Given this list of marker genes RNA5S6, LUZP2, RCBTB2, ADAT2, PGM5P2, MYC, KCNAB2, PTGES3L, SNX16, NPEPL1, TRBV7-7, LINC00887, LINC00310, IQCE, ST8SIA6-AS1, TRHR, SPATA42, BASP1, NRSN2-AS1, GPHA2, LINC02645, SELENBP1, OPN4, ACSF2, NRG2, NDNF, GOLGA6L22, KIAA0319, APLP1, SLC24A4, MMP16, HYCC1, C4orf17, BLK, GABRA1, AMPH, OTP (NCBI Gene Id 23440), GAL3ST4, TTC9-DT, OTOG, KIF9, LINC02000, NRSN2, NOX4, SLC25A15, AMOTL2, NT5DC4, DUOX1, HSPA8P14, TRPM8, LHX8-AS1, TMEM95 (NCBI Gene Id 339168), SNORD13D, DENND4B, COL11A1, USP30, AMPD3, CTSK, ADGRG1, RD3, TTC9, MTRES1P2 (NCBI Gene Id 100129168), COLQ, SEMA6A, MEF2C-AS1, JPH4, COLGALT2, SOX5, EMB, PRKG1, BASP1-AS1, CUX1, here is a description of the gene set: from publication Yevshin I, Sharipov R, Kolmykov S, Kondrakhin Y, Kolpakov F (PMID 30445619) Human Gene Set: NME2_TARGET_GENES species: Homo sapiens Genes containing one or more binding sites for (NME2) in their promoter regions (TSS -1000,+100 bp) as identified by GTRD version 20.06 ChIP-seq harmonization.